Given this list of marker genes SNX16, PIAS2, PTMS, SLC6A4, ATAD1, CDK16, PLAGL2, SLFN12L, RNF17, HSPB3, RAB10, TBC1D13, CAVIN2, LMO4, YIPF7, ECE2, MDFIC, ITGB1, IDS, NEU1, IREB2, RTN4, VPS54, SERTAD1, CTSC, GCC1, PTPRJ, TMA16, C2orf74, ETV3, RNPEP, GTPBP2, LAP3, VPS72, TAL1, ZBTB7A, HOMER1, HMGA1, PDCD6IP, FRMD8, ABCG2, IGSF8, SH3TC1, GCA, MYNN, FST, PPP1R2P1, SYNPO2, DYRK1A, PADI3, ZNF277, NOG, GNA13, RGL1, IDUA, KRTDAP, MCMBP, ABHD10, CHIC2, RNF114 (ring finger protein 114), NDP, CBLN1, G3BP2, ENDOD1, ESD, VWA5A, ST3GAL5, HMGXB3, NDRG2, HTRA2, SH3KBP1, MRPL39, DIDO1, COG6, UPP1, MTF2, UBE2N, CENPE, TMEM39A, KITLG, RND3 (Rho family GTPase 3), ITPR1, SLC25A45, MAN1A2, ARHGAP17, FUT7 (fucosyltransferase 7), GKAP1, TMEM106A, MAP3K8, SMC5, ARF4, PTPRE, VRK2, PPP1CB, EXOC1, CLK3, PSMB8, NR3C1, TMEM192, RILPL1, PEX26, MBD6, SLC28A2, CEP350, BCKDHB, DHX58, ZNF436, SEPTIN7, LUC7L3, RBM43, BLOC1S6, HAT1, MCL1 (MCL1 apoptosis regulator, BCL2 family member), INSM1, ATP6V0A2, TRAF4, PCNA, DLGAP4, SLC37A3, ZDHHC5 (zinc finger DHHC-type palmitoyltransferase 5), OAZ2, GATAD2A, CNN3, HCAR2, ZNF410, TGM2, NOS2, UBN1, VCL, IL1RN, STK38, NAA30, MOB1A, MYOT, CCDC6, EIF2S2, MTFR2, SPTLC2, ADAMTS1, IRGM, METTL6, MAP3K5, HACE1, EBI3, IFT57, TRIM25, STAG1, MMP14, PGAP4, TMEM38B, PBX2, BLOC1S4, TBL1X, EFHD2, SPTLC1, SRPK3, CD164, CACNA1D, LIMA1, MSN, IRF8, ZBP1, POLR3F, FHL5, ZNF841, DDX4, LNX1, ZDHHC20, PPP1R15B, CDKN1A, LDLR (low density lipoprotein receptor), KLRK1, CAV1, TBPL1, ADORA1, TAB2, PTPN6, INHBB, NUDT9, RAB33B, NANOG, CCNE1, NINJ1, TAF12, MMP2, RALGDS, HDAC1, EDNRA, VEGFC, CILK1, FBXW11, PDE7B, PHC2, ATF3, TM9SF3, CELA3B, TNRC6A (trinucleotide repeat containing adaptor 6A), CROT, CD70, here is a description of the gene set: Human Gene Set: GSE17721_0.5H_VS_8H_POLYIC_BMDC_DN mouse primary BMDCs were stimulated with tlr ligands and gene expression changes were profiled on Affymetrix arrays studied in species Homo sapiens Genes down-regulated in comparison of dendritic cells (DC) stimulated with poly(I:C) (TLR3 agonist) at 0.5 h versus those stimulated at 8 h. from publication Amit I, Garber M, Chevrier N, Leite AP, Donner Y, Eisenhaure T, Guttman M, Grenier JK, Li W, Zuk O, Schubert LA, Birditt B, Shay T, Goren A, Zhang X, Smith Z, Deering R, McDonald RC, Cabili M, Bernstein BE, Rinn JL, Meissner A, Root DE, Hacohen N, Regev A (PMID 19729616)